The following is a description of a gene set: Human Gene Set: MODULE_169 Immune response. studied in species Homo sapiens, and this is the list of marker genes: DENND3, DDA1, MICAL2, NPIPB3, SVEP1, XCL1, PCDHGC3, ADA, HTR3A, ZNF16, CYBB, RGS16, SORL1, BMP7, TNS3, CRLF3, DAPK1, ULK1, SCD, CCL4, CD86, RGS1, HEATR5A, HCK, BCL7A, CREG1, FOS, TSPAN7, DHRS9 (dehydrogenase/reductase 9), KLF10, TXN, CD2, CDK6, MYBL1, ID2, IL15RA, ASB13, RGL3, SCAND2P, USP2, AHR, SMAD7, STK17A, H1-2, STAG3, CRIP2, DUSP2, STMN1, ABCC1, SERPINA5, GFOD3P, CACNA1A, SON, TOX, ATP2C1, TNFAIP8L2, KCNJ5, DTX1, MT2A, KAT2A, JUP, CLGN (NCBI Gene Id 1047), PSMB8 (NCBI Gene Id 5696), CCL3, IER3, LMO2, RGS13, IL7R, PAG1, CCL5, ITGA4, GNG10, BIK, HLA-DOA, MME, BCL2A1, LINC01949, IL32, STIM2, TRIB2 (NCBI Gene Id 28951), ITGB2, ZNF608, CAMK4, RIPK3, AICDA, ISG15, CD3D, MAL, IL2RB, CR2, PRKAR2B, SLC39A10, KLHL6, SLC2A5, BCL6, AGA, KLRK1